Given this list of marker genes Lhcgr, Nr3c1, Hsd17b1, Bmp5, Gm2044, Aanat, Mir205hg, Cacna1a, Stc2, Srd5a1, Arnt, Tpo, Hfe, Ffar3, Wnt4, Nr5a2, Gfi1, Hsd17b3, Igf1r, Hsd17b12, Dab2, Srd5a2, Scarb1, Dio1, Tg (thyroglobulin), Rest, Bmpr1b, Atp1a1, Cyp11b2, Chst8 (NCBI Gene Id 68947), Dgkq, Dio2, Cyp21a1, Cyp27b1, Fdx1, Stard3, Ppargc1a, Dkk3, Igf1, Clcn2, Cyp17a1 (cytochrome P450, family 17, subfamily a, polypeptide 1), Hsd3b2, Bmp2, Med1, Igf2, Hsd17b7, Hif1a, H6pd, Hsd3b6, Dhrs11, Star, Por, Cyp11b1, Hsd17b2, Scp2, Cyp27a1 (cytochrome P450, family 27, subfamily a, polypeptide 1), Cyp11a1, Dio3, Nfkb1, Cacna1h, Asmt, Psg18, Gh, Cyp19a1, Akr1c14, Hsd3b1, Egr1, Hsd3b3, Hsd17b8, Bmp6, Pde8b, here is a description of the gene set: Mouse Gene Set: GOBP_HORMONE_BIOSYNTHETIC_PROCESS The chemical reactions and pathways resulting in the formation of any hormone, naturally occurring substances secreted by specialized cells that affects the metabolism or behavior of other cells possessing functional receptors for the hormone. species: Mus musculus